Given this list of marker genes GADD45G, HOXC13, RBPMS2, SERPINE1, SPCS3, ARID4B, PAICS, RAD52, NDRG4, LHX2, CCPG1, ECI2, BLTP1, GP2, NUS1, AHI1, CLYBL, RUFY3, SNX18, PSMD6, SGK2, DPH7, CAPRIN1 (NCBI Gene Id 4076), MAP3K5, ZNF518B, ZSCAN12, VPS28, BBS2, SATB1, SLC25A46, ELOC, GSR, ZSCAN26, TASP1, MT2A, UBE2D1 (ubiquitin conjugating enzyme E2 D1), GRAMD1A, MAP3K8, TRIB2, CCR2, GPR180, C6orf62, UBR3, SIGIRR, UBE2H, TNRC6B, FBLN7, SLF2, AK4, DGAT1, SPP1, NFIL3, HAUS3, TDO2, KMT5B, SAMD10, ELOVL6, HLX, PECAM1, ENOX2, TTC33, KRTAP15-1, MBD2, SLC41A1, GRIN2C, PRXL2C, IYD (NCBI Gene Id 389434), NCKIPSD, FLOT2, MMS22L, LAMP2 (NCBI Gene Id 3920), NGLY1, ELOVL7, SMAD6, RIPK2, ZMYM1, RPN2, AUH, PRUNE1, CCDC71L, PRNP, GPX2 (NCBI Gene Id 2877), HOXB4, PKP1, HBG2, CSTPP1, RFC3, WNT5B, PRP4K, PIP4P2, ZFP36, DTD1, PDCD10, GEMIN8, DAG1, PGS1, ARHGEF10, PHPT1, ERC1, RNF146, ENPP2, POU6F1, CENPA, CYP11B2, PSENEN (presenilin enhancer, gamma-secretase subunit), MRI1, SLC25A36, LPP, DUSP11 (NCBI Gene Id 8446), RPP40, RHEBL1, ATG101, MFSD6, AR, HOXD8, NFS1, LAPTM4B, KLHL42, GAL3ST1, NLK, TMED8, PXMP4, TDRD3, MRC1, AAMP, REEP1, ALOX12B, GPR65, MAF1, BLOC1S3, CPEB2, BNIP3L, ATF6, INPP5A, RAD51D, DLG5, BCL6B, DPF1 (double PHD fingers 1), CCL1, GOLGA7 (NCBI Gene Id 51125), MTIF2, NUDT21 (NCBI Gene Id 11051), GPR146, SAT1, TTC39C, SKAP2, CNOT4, ZNF260 (zinc finger protein 260), FRMD6, ADI1, SPINT2, PGM1, IL17D, TBX21, HACD1, KLF9, IL17RA, ACKR3, RIPK3, AP5S1, SDC3, CASQ2, ATP6V1H, SLC30A4, REV1, ZC3H12C, CCDC34, GABBR1, HAUS4, SPRYD3, EFR3A, PCMTD2 (protein-L-isoaspartate (D-aspartate) O-methyltransferase domain containing 2), SLC35B4, SLC25A51, ZNF707, GBP2, SPINK4, HYCC2, SERPINB1, PAPOLA, PIK3R2, HSD17B10, ECPAS, FKBP11, ALPK2, UNC119B, GUCA1B, MFSD11, CTBS, YTHDC1, PIK3R4, CPQ, MYH4, MARCHF6 (NCBI Gene Id 10299), ERRFI1, CDKN2D, NAA30 (N-alpha-acetyltransferase 30, NatC catalytic subunit), FAM118B, KIF2A, MAFK, here is a description of the gene set: species: Homo sapiens Transcriptional profiling of NKAES-derived NK cells after 7 days of culture compared to primary human NK cells and NK cells stimulated by low or high dose IL2 after 7 days of culture. from publication Fujisaki H, Kakuda H, Shimasaki N, Imai C, Ma J, Lockey T, Eldridge P, Leung WH, Campana D (PMID 19383914) Human Gene Set: GSE12198_NK_VS_NK_ACT_EXPANSION_SYSTEM_DERIVED_NK_CELL_UP Genes up-regulated in NK cells: primary versus activated and expanded.